The following is a description of a gene set: Genes predicted to be targets of miRBase v22 microRNA hsa-miR-3972 in miRDB v6.0 with MirTarget v4 prediction scores > 80 (high confidence targets). from publication Chen Y, Wang X (PMID 31504780) studied in species Homo sapiens Human Gene Set: MIR3972, and this is the list of marker genes: DICER1, SOS1, MS4A12, EGLN2, LRP4, ZFHX4 (zinc finger homeobox 4), TOX, CTNND1, EIF4E2, MED23, SLC38A1, TMEM87A, ZNF365, SLC18A2, MAX, ZBTB34, RRP1B, LRRC8C, EFNA5, TMEM215, ACTG1, CNST, PAK5, NR2C1, CHSY3, RRN3, PSMD12, ANAPC16, NUMBL, NDFIP2, LAMP5, ABLIM1, FTSJ1, SRPK2, CDK14, TLE3 (NCBI Gene Id 7090), PAK2, ZBTB43 (NCBI Gene Id 90789), BCL6B (BCL6B transcription repressor), SHE, SELENOT, BNIP5 (NCBI Gene Id 389384), MAN2B2, ZDHHC21, ZNF195, ARID4B, FMO5, KDM6A, PPP1R14C, CRISPLD1, SULT4A1, OSBPL11, MCTP2, TMEM263, ZDHHC18, RALBP1, PTPN20, HNF4A, PLPPR4, LUZP1, EML4, BICRAL, DMTF1, CDH5, ABCA1, COLEC10, NDST3, CCR5, LILRA5, HLA-DRA